The following is a description of a gene set: Human Gene Set: GOBP_MYELOID_CELL_DEVELOPMENT The process whose specific outcome is the progression of a myeloid cell over time, from its formation to the mature structure. studied in species Homo sapiens, and this is the list of marker genes: RAC1, PTBP3, SLC9B2 (NCBI Gene Id 133308), GP1BB, MPIG6B, FLNA (filamin A), ZNF385A (NCBI Gene Id 25946), EP300, NCKAP1L, GP1BA, DMTN, FAM20C, GPR68, MAEA, MED1, ANXA2, TYROBP, EVI2B (NCBI Gene Id 2124), ALAS2, ZFPM1, JMJD6, TMOD3, DIAPH3, NRROS, VPS33B (VPS33B late endosome and lysosome associated), LYAR, SIGLEC15, RHEX, PTPN6, WASF2, ZBTB7A, BPGM, G6PD, PIP4K2A, HDAC6, LTF, ATP6AP1, EPB42, RAC2, HBZ, LRRK1, APP, GP9, TSPAN2, BCL6, PAFAH1B1, NOTCH2, ABI1, LILRB1, KLF2, GATA1, P2RX5, TNFSF11 (NCBI Gene Id 8600), BAP1, PABPC4, FOXP1, ARID4A, GP5, FAM210B, KIT (KIT proto-oncogene, receptor tyrosine kinase), SRC, SLC25A40, ALAS1, THPO, SLC11A2, CEBPB, FLVCR1, SRF, PLA2G10, TAL1, EPO, ABCB10, SLC4A1, CITED2, RHAG, ADGRF5 (adhesion G protein-coupled receptor F5), FBXW7, FBN1, TLR2, TRIM58, MYB, HEATR3, NEMP1, BRD1, PTPN11 (NCBI Gene Id 84990), ERCC2, MEIS1, FLI1 (NCBI Gene Id 2313), CLDN18, L3MBTL3, SH2B3